The following is a description of a gene set: Serotonin and melatonin biosynthesis species: Mus musculus Mouse Gene Set: REACTOME_SEROTONIN_AND_MELATONIN_BIOSYNTHESIS, and this is the list of marker genes: Asmt, Ddc, Tph1, Tph2, Aanat